Given this list of marker genes Hsd17b3, Hsd17b8, Hsd17b2 (NCBI Gene Id 15486), Dhrs9, Hsd17b6, Hsd17b1, Hsd17b10, Hsd17b4, here is a description of the gene set: species: Mus musculus Mouse Gene Set: GOMF_17_BETA_HYDROXYSTEROID_DEHYDROGENASE_NADPLUS_ACTIVITY Catalysis of the reaction: a 17-beta-hydroxysteroid + NAD+ = a 17-oxosteroid + NADH + H+.